Given this list of marker genes ARSB, here is a description of the gene set: part of: Mucopolysaccharidoses Mucopolysaccharidosis type VI (MPS VI, Maroteaux-Lamy syndrome, polydystrophic dwarfism; MIM:253200) is an autosomal recessive lysosomal storage disorder caused by a deficiency in arylsulfatase B (ARSB, N-acetyl-galactosamine 4-sulfatase; MIM:611542). It is named after two French physicians, Pierre Maroteaux and Maurice Emil Joseph Lamy. Maroteaux first described this disorder as a novel dysostosis associated with increased urinary excretion of chondroitin sulfate (CS; Maroteaux et al. 1963). The gene encoding ARSB is mapped to chromosome 5q11-q13 and contains 8 exons spanning about 206 kb. Defective ARSB results in build up of dermatan sulfate (DS) and chondroitin sulfate (CS) in soft tissues causing compression and blockages in blood vessels, nerves, trachea, corneal clouding and disrupting normal bone development. Symptoms are similar to MPS I but with normal intelligence generally. species: Homo sapiens Reactome Pathway: MPS VI - Maroteaux-Lamy syndrome